Given this list of marker genes RPS9, MCFD2 (NCBI Gene Id 90411), NENF (NCBI Gene Id 29937), MICOS10, DPCD, SAA1, HS6ST2, ESS2, SNX1, HSD17B10, MAP3K3, SLC15A3 (solute carrier family 15 member 3), DCBLD2, ACKR3, BLTP3A, HOOK2, FOLR2, TMA7, CXCL2 (NCBI Gene Id 2920), PTS, TRIP10, HRG, DDX41, SLC30A9, ATP5IF1, PRTN3, AVPI1, AK4, TAOK3, LOXL3, ATP5PB (ATP synthase peripheral stalk-membrane subunit b), HK2, NUPR1, SLC18A3, ATP7A, DNAJC13, ABHD17B, IL3RA, BHLHE40 (basic helix-loop-helix family member e40, NCBI Gene Id 8553), SLPI, DYNLT1, FAM162A (NCBI Gene Id 26355), GJA1, ENC1, CNN3, DHRS3, DNAAF10, FRG1, SYPL1, SYF2, SRRM2, GABARAPL2, POGLUT3, COX14, FSTL1, NICOL1, VEGFA, CYB5R3, AURKAIP1, ETHE1, CFP, PGRMC2, CD14, DKK2, DBNDD2, CAMKK1, METRNL, PLOD1, CCDC68, LXN (latexin), GON4L, PTPRG, NUP214, URI1, HIC1, ITGA6, RHOC, CFH, LETM1, S100A8, LHCGR, ERGIC1, MAP2K1, RAB24, SDF4, FCGR1A, BAMBI, SLC24A3, SELENOK, VPS39, C3orf85, PILRB, ZFP36L1, ZNF292, ARRDC2, BAD, PPIH, ANAPC15, ARID5A, NUAK1, NDUFA6, UQCC5, RGS16, RPTOR, DNAH6, LMCD1, RAB20, TNFSF14, DACH1, GPX1, RPL31, MYL6, MAF, NDUFA2, DCAKD, BRI3, TIMM8B, ALKBH4, TSPAN18, CH25H, MTLN, MMP9 (NCBI Gene Id 4318), COL4A5, RIPOR3, EBI3, ZNF707, ZBTB8OS, MEF2D, DNAH2, HP, CRABP1, DHDH, RTN4RL1, C3orf70, SGCG, CCRL2, GALNT2, FOLR1, NPPC, RGP1, CYP26B1, COL4A1, IFNAR2, NSMCE2, UBTD1, ZMIZ1, PRKCA, RPL26, AGTRAP, SEPTIN4, NCBP2AS2, MED18, SLC25A18, LRFN3 (leucine rich repeat and fibronectin type III domain containing 3), FAM216A, PRKAB1 (NCBI Gene Id 5564), CCDC24, LENG9, SNAPC5, AQP9, NDUFA3, FPR1, NRIP1, OSM, ANTXR1, RPL22L1, DCTN3, COPE, PDCD2L, GPAT3, ADGRA2, DDIT4, SMAD3, AOAH, SCARF1, UQCC2 (NCBI Gene Id 84300), CYFIP1, FRK, KMT2C, MTDH, TMEM223 (NCBI Gene Id 79064), NPM3, FEZ2, RPL22, YAP1, COL14A1, SERINC1, PRRT3, DDC, CCDC32, PI4K2B, TIMM13, GTF2H5, SERPINE1, GP1BA, ARPP19, COMT, NDUFS6, FLYWCH1, EPAS1, here is a description of the gene set: from publication Derbinski J, Gäbler J, Brors B, Tierling S, Jonnakuty S, Hergenhahn M, Peltonen L, Walter J, Kyewski B (PMID 15983066) species: Homo sapiens Genes up-regulated in thymic epithelial cells: cortical (cTEC) versus medullary (mTEC). Gene expression in different thymic stromal cells and subsets thereof was analyzed in 6-12 week old wild type (C57BL/6) and Aire knock-out (mixed background) mice. Thymic stromal cells were purified by sequential enzymatic digestion (collagenase, collagenase/dispase and trypsin) followed by gradient centrifugation and FACS sorting. Sort criteria were as follows: dendritic cells (CD11c+, F4/80 -), macrophages (F4/80+, CD11c-), cTECs (CD45–/lo, CDR1/Ly51+, Ep-CAM+) and mTECs (CD45–/lo, CDR1/Ly51–, Ep-CAM+). mTECs of wild-type and Aire knock-out mice were further subdivided according to CD80 expression levels. For microarray analysis total RNA from thymic stromal cell samples of two independent experiments was pre-amplified and biotinylated by two rounds of cDNA synthesis and in vitro transcription. Fluorescence readings were evaluated by using Microarray Suite 5.0 software. Human Gene Set: GSE2585_CTEC_VS_MTEC_THYMUS_UP